The following is a description of a gene set: species: Homo sapiens Human Gene Set: GSE27786_CD4_TCELL_VS_NKCELL_UP Each fraction of mouse hematopoietic cells was purified by cell sorting from bone marrow of 8-week-old C57BL/6 mice, and its gene expression was analyzed. Genes up-regulated in comparison of CD4 T cells versus NK cells. from publication Konuma T, Nakamura S, Miyagi S, Negishi M, Chiba T, Oguro H, Yuan J, Mochizuki-Kashio M, Ichikawa H, Miyoshi H, Vidal M, Iwama A (PMID 21540074), and this is the list of marker genes: UBL4A, LRRC3, FOXK2 (NCBI Gene Id 84213), XXYLT1, ZNF362, EBP, BCLAF1, AKAP9, ABT1, IGFBP7, AFP, PDE2A, FOSB, KIF3A, LRCH2, IP6K2, GLRX, ADORA1, WNT10B, NDP, CSGALNACT1, RNF14, HNRNPC, SUN2, PDGFD, TCF12, WASHC3, TRIM59, SP4, ME3, DESI2, TAP2, ELMOD3, ATP8A2, C21orf58, RC3H1, INTS6, CEP95, TRMT10C, NDUFAF5, GBX2, IL13RA2, RGS20, IWS1, RMDN3, TTC13, RLF, NTAN1, TCAF1, AMN, COA4, GABPB1, NSUN5, NCOR1, TMEM252, GYPC, GPBP1, ING1, PARP3, PPM1K, ZNF292, TSPAN13, CHCHD3, DRC12, TADA2A, ADAMTS8, EPB41, CNR1, SNRNP200, ZFP41, NUDT6, ACAP1, CYSTM1, PSPH, DGKZ, RAB37, DBP, KCNC2, CYLD (NCBI Gene Id 8010), PLIN5, METTL3, GABRR2, AKAP8, ITGB3, DPY30, GAK, ZNF239, RBM5, PPP2R2A, DNAH8, KMT2A, GABRG1, SNRPN, SLCO3A1, TTLL12, NHERF1, AAMDC, FOCAD, CD247, MRPS24, KLHL35, ZXDC, ZP3, SCG5, ZMYND8, HERC2, RPS8, ASB3, CDK10, IFIT1, OSTC, SLC4A7, PHPT1, PHTF1, GPT, LDB1, DDX47, ADGRL3, RPL27, THAP12, GIMAP6, RPF1, SLC39A14, LRRN2, PAN3, SLC6A7, CYP4F12, USP39, NDRG3, CCDC6 (coiled-coil domain containing 6), ADCY6, CCDC82, PNRC1, ETNK1, MRPL58, ADI1 (NCBI Gene Id 55256), DNAH7, C3orf38, ZNF251, PSMA3, GRAMD1A, SUCO, FXYD6, TOMM7, USP34, SETD6, BIN1 (NCBI Gene Id 274), TNFRSF18, LRRN4, CA14, SUPT20H, GPRIN3, DDB2, RGS8, NBR1, GPR15, LPCAT1, FAM222A, SNHG6, PTPN21, ZZZ3, PPCS, SESN3, DBR1, PJA1, ABCA4, FLNB, NUDCD2, EMG1, PRSS22, AGFG1, METTL18, NOP53, CAPSL, MSL2, CYP2D6, CNPY2, LYPLA2, ZNF560 (zinc finger protein 560), PTTG1, PHKG2, TNRC6C, ARHGAP31, DYRK2, HCST, GRM5, STK4, CHCHD10, RGCC (regulator of cell cycle), IGFLR1, MEAF6, MAP4K1, NLK, SNHG17, FHIP1A, TRAF3IP3, RINL, ATP8B2, C22orf39, EPHB6 (NCBI Gene Id 2051)